Given this list of marker genes SAP30, CTSD, PTPN22, NECTIN1, ABCC5, SIGMAR1, MRPL21, EBP (EBP cholestenol delta-isomerase), CIAO3, NAA40, CD68, TFDP1, BEND7, BBLN, ACAD9, SYTL3, PADI4, GRAMD4, CEBPZOS, GPAT4, CRISP3, ADAM19, CD1D (CD1d molecule), COA6-AS1, SYCP2, PF4V1, TTC38, PLD3, TCN1, DPP7, COA6, ACBD6, SH3RF3, PLCB3, LRP3, NRIP1, PNPLA1, GALNT14, SEPTIN5, NT5DC1, DGKG, RUBCNL, TM7SF3, CMTM8, ADK, RSU1, EDARADD, TESC, AUH, TSR2, FLT1, TBC1D3B, REX1BD, LRRC75A, PPDPF, HSPE1, SNRNP25, ITPKB-IT1, NDUFA7, OPLAH, HOMER3, ARIH2OS, TMEM39B, here is a description of the gene set: Genes down-regulated in neutrophil 1d vs 0d in adults after exposure to 2011-2012 trivalent inactivated vaccine (A/California/7/09 (H1N1), A/Perth /16/2009 (H3N2), B/Brisbane/60/2008), time point 1D. Comment: Down-regulated DE RNA transcripts (down >= 1.5x) shared between both TIV-vaccinated donors from publication Hoek KL, Samir P, Howard LM, Niu X, Prasad N, Galassie A, Liu Q, Allos TM, Floyd KA, Guo Y, Shyr Y, Levy SE, Joyce S, Edwards KM, Link AJ (PMID 25706537) studied in species Homo sapiens Systems biology is an approach to comprehensively study complex interactions within a biological system. Most published systems vaccinology studies have utilized whole blood or peripheral blood mononuclear cells (PBMC) to monitor the immune response after vaccination. Because human blood is comprised of multiple hematopoietic cell types, the potential for masking responses of under-represented cell populations is increased when analyzing whole blood or PBMC. To investigate the contribution of individual cell types to the immune response after vaccination, we established a rapid and efficient method to purify human T and B cells, natural killer (NK) cells, myeloid dendritic cells (mDC), monocytes, and neutrophils from fresh venous blood. Purified cells were fractionated and processed in a single day. RNA-Seq and quantitative shotgun proteomics were performed to determine expression profiles for each cell type prior to and after inactivated seasonal influenza vaccination. Our results show that transcriptomic and proteomic profiles generated from purified immune cells differ significantly from PBMC. Differential expression analysis for each immune cell type also shows unique transcriptomic and proteomic expression profiles as well as changing biological networks at early time points after vaccination. This cell type-specific information provides a more comprehensive approach to monitor vaccine responses. Human Gene Set: HOEK_NEUTROPHIL_2011_2012_TIV_ADULT_1DY_DN